Given this list of marker genes RPS27A, RPL15, RPL26L1, RPS21, RPS16, RPL14 (ribosomal protein L14), RPS5, RPS23, SEPSECS, RPL23, SECISBP2, RPS17, RPL37, RPS19, RPS20, RPS29, RPL34, RPL6, RPS3, RPS11, RPL10A, RPL39L, RPS13, RPL19, SARS1, RPL35A, RPL29, RPL30, FAU, RPS28, RPL9, RPL8, RPL38, RPL3L, RPL21, RPS2, RPS10, RPL4, 5.8S rRNA, RPL36AL (ribosomal protein L36a like), RPS26 (ribosomal protein S26), RPS27, RPS8, RPS3A, RPS15A, RPS9, RPL11 (NCBI Gene Id 6135), RPSA, RPL13 (ribosomal protein L13), PSTK, RPL41, RPL35, RPL7A, SEPHS2, RPLP1, RPL37A, RPL27, RPL10L, RPS12, RPL13A, RPS7, RPS27L, RPLP0, RPS6 (ribosomal protein S6), RPL5, RPL3, RPL28, RPL10, RPL12, RPS25, RPS4Y1, RPL7, 28S rRNA, RPL31, RPS14, RPL18, RPS24, RPL36, RPL18A, RPLP2, RPL36A, RPL17, RPL27A, 18S rRNA, 5S rRNA, RPL39, RPS4X, RPL26, RPL22L1, EEFSEC, RPS15, RPS18, RPL23A, RPL32, RPL24, UBA52, RPS4Y2, RPL22, here is a description of the gene set: Reactome Pathway: Selenocysteine synthesis part of: Selenoamino acid metabolism Selenocysteine, the 21st genetically encoded amino acid, is the major form of the antioxidant trace element selenium in the human body. In eukaryotes and archaea its synthesis proceeds through a phosphorylated intermediate in a tRNA-dependent fashion. The final step of selenocysteine formation is catalyzed by O-phosphoseryl-tRNA:selenocysteinyl-tRNA synthase (SEPSECS) that converts phosphoseryl-tRNA(Sec) to selenocysteinyl-tRNA(Sec). studied in species Homo sapiens